Given this list of marker genes Acp5, Ctsz, Syk, Tbl3, Ctsk (NCBI Gene Id 99590), Csf2rb, Lcn2, Myo7a, Pou3f2, Cstb, Socs3, Tceal9, Clec4a2, Pira1, Sat1, Mpeg1, Ago2, Lrp5, Sncb, Ccn3, Gja5, Ptgdr2, Cfl1, F7, Pigt, Ifitm10, Cavin1, Axin2, Bcl2l11, Adam15, Lyz2, Ctsd, Ccl3 (NCBI Gene Id 20302), Sh3rf1, Pdia4, Plet1, Apoc1, Itgax, Ccl6, Lpl, Ly75, Basp1, Usf1, Rap2b, Spp1, Sema6a, Wfdc21, Pld3, Agpat1, Ctss, Cd68, Cotl1, Lrg1, Snd1, Smap2 (NCBI Gene Id 99975), Agap3, Rasgrp2, Iqgap1, Atg7, Tle5, Csf2rb2, Scd1, Psma4, Sp4, here is a description of the gene set: from publication Stearman RS, Dwyer-Nield L, Grady MC, Malkinson AM, Geraci MW (PMID 18172294) Down-regulated genes classifying non-tumor lung tissues by age after incution of lung cancer by urethane injection: early (24-26 weeks) vs late (46 weeks). Mouse Gene Set: STEARMAN_LUNG_CANCER_EARLY_VS_LATE_DN One area of intensive investigation is to understand complex cellular and signaling interactions in the tumor microenvironment. Using a novel, although straightforward, microarray approach, we defined a gene expression signature from the lung tumor microenvironment in the murine A/J-urethane model of human lung adenocarcinoma. The tumor microenvironment is reflected by the composition of the cell types present and alterations in mRNA levels, resulting in a Field Effect around the tumor. The genes composing the Field Effect expression signature include proteases and their inhibitors, inflammation markers, and immune signaling molecules. By several criteria, the Field Effect expression signature can be attributed to the macrophage lineage, suggesting a qualitative change in the expression pattern of tumor-associated macrophages (TAM) observed in lung tumors. The protein expression levels for a number of Field Effect genes were verified by Western blot analysis of lung homogenates, and for their expression in macrophages and parenchymal cells outside of the tumors by immunohistochemistry. In addition, the Field Effect expression signature was used to classify bronchoalveolar lavage (BAL) cells from tumor-bearing or age-matched control mice. Using a variety of statistical measures, the Field Effect expression signature correctly classified the BAL cells >94% of the time. Finally, the protein levels for several Field Effect genes were higher in cell-free BAL fluid, indicating they may be secreted by the TAMs. This work suggests that TAMs generate a unique gene expression signature within the tumor microenvironment, and this signature could potentially be used for identifying lung cancer from BAL cells and/or fluid. species: Mus musculus